Given this list of marker genes CSF1R, C1QL1, DLG1, CBLN2, DCTN1, PLEKHA7, F2R, RAB3A, SHANK1, NLGN2, F2RL1, PCLO, CLDN3, GRN, RIMS3, SDF4, ADGRB3, RIMS1, FERMT2, ARF6, BSN, CBLN3, CD177, PRICKLE1, ITGB3, PRTN3 (NCBI Gene Id 5657), INAVA, TJP1, PLXNA4, MYADM (NCBI Gene Id 91663), PKP1, APPL1, CAMSAP3, CHCHD10, RIMS2, ERC2, GIT1, DSC1, CNTNAP1, OPHN1, CSMD2, RAPSN, ERC1, MTSS1, KIFC3, PPFIA2 (PTPRF interacting protein alpha 2), CBLN1, KIRREL1, PARD6A, SORT1, WHRN, CLDN1, SYNGAP1, here is a description of the gene set: Human Gene Set: GOBP_CELL_JUNCTION_MAINTENANCE species: Homo sapiens The organization process that preserves a cell junction in a stable functional or structural state. A cell junction is a specialized region of connection between two cells or between a cell and the extracellular matrix.